The following is a description of a gene set: Genes having at least one occurrence of the highly conserved motif M79 WGGAATGY in the regions spanning 4 kb centered on their transcription starting sites. This matches the TEAD1 transcription factor binding site V$TEF1_Q6 (v7.4 TRANSFAC). Human Gene Set: WGGAATGY_TEF1_Q6 studied in species Homo sapiens from publication Xie X, Lu J, Kulbokas EJ, Golub TR, Mootha V, Lindblad-Toh K, Lander ES, Kellis M (PMID 15735639) Comprehensive identification of all functional elements encoded in the human genome is a fundamental need in biomedical research. Here, we present a comparative analysis of the human, mouse, rat and dog genomes to create a systematic catalogue of common regulatory motifs in promoters and 3' untranslated regions (3' UTRs). The promoter analysis yields 174 candidate motifs, including most previously known transcription-factor binding sites and 105 new motifs. The 3'-UTR analysis yields 106 motifs likely to be involved in post-transcriptional regulation. Nearly one-half are associated with microRNAs (miRNAs), leading to the discovery of many new miRNA genes and their likely target genes. Our results suggest that previous estimates of the number of human miRNA genes were low, and that miRNAs regulate at least 20% of human genes. The overall results provide a systematic view of gene regulation in the human, which will be refined as additional mammalian genomes become available., and this is the list of marker genes: MMP23A, PTMS, DLG3, MID1, PCBP1, RRAS, CDH3, ARHGAP24, NDST4, CHRNA1, SH3RF1, TENT5B, SEPTIN4, FGA, TSPAN9, SLC12A5, MMP1, LMNA, CRLF1, IL6ST, CDC42EP1, SPTB, EFNB3, DVL3, CACNA1G, VIT, NTF4, KLHDC3, FAM50A, HAND2, NUFIP2, RNF2, CPLX2, ZNF827, MYPN, HNRNPLL, NRG1, TRIM54 (tripartite motif containing 54), TFDP2, MAN1A2, MEA1, ADAM33, KCNE2, SLC26A6, SPRED1, CLDN16, TRAF4, SOSTDC1, GAS2L2 (growth arrest specific 2 like 2), TSPYL4, MAPRE3, PRRG4, CALHM4, GLP2R, ITGB1BP2, MNT, PGF, MDK, COA3, LIFR, MTSS1, GREM1, PRDM1, CYP2W1, LINC01567, FOXN1 (NCBI Gene Id 8456), MGLL, AP2M1, EPHA2 (NCBI Gene Id 1969), TGIF1, HOXC13, KRT14, DENND2B (DENN domain containing 2B), PTH1R, PGAM2, MLIP (muscular LMNA interacting protein), SYT2, EPCIP, LAMC2, HSPB2, ROGDI, RADIL, RHBDF1, CTTNBP2NL, PAQR6, RRN3P1, C10orf71, RAB30, NOTCH2NLA, PRUNE1, NFKB2, MPZ, COL5A3, SPDEF, CNN3, DIAPH1, CDK2, DACT1, ZNF462, INHBA, KALRN, PRKCI, IER5, CRYAB, LINC00482, NHERF1, RPH3AL, CHIC2, KLK6, DDX23, GALNT12, PTPRJ, SCARF2, CCN1, SIPA1, SIN3A, APOE, PPFIA1, ROCK2, PLS3, CAVIN1, SH2B3, PKP4, FOXP2, SORBS2, REST, CLRN1, PTCH1, SPEG, SPACA7, JUND, COL4A5, TNS2, CCDC148, ITGA3, PRSS27, CCN2, LRRN4CL (NCBI Gene Id 221091), HOXA10, MLLT3, CEND1 (NCBI Gene Id 51286), RNF19A, MGAT4C, CCSER2, ZC3H10, TMSB4XP1, WIPI1, SMOC2, GDI1 (GDP dissociation inhibitor 1), HOXB3, CALCOCO1, TBXT, NID1, SMAD3, SOST, WDR13, UNC13D, JADE1, DENND1B, MMGT1, ATRN (attractin), APPBP2, PLEKHH3 (pleckstrin homology, MyTH4 and FERM domain containing H3, NCBI Gene Id 79990), SLC5A2, DUSP7, OTX2, SGIP1, COLEC10, NTN3, TINAGL1, NES, SEC14L3, TMEM86A, COL4A6, SH3BP1, CFL2, PLPP5, POGZ, ANKRD11, ESR1, MAST2, SH3BGRL2, VCL, MUSK, KMT2E (lysine methyltransferase 2E (inactive)), KAT14, CDKN2C, ATF4 (activating transcription factor 4), CAVIN3, CORO6, NNMT, PDGFRA, ADPRHL1, TGIF2, GHRL, KCNJ13, ATP5MC2, ITPR3, NTN5, SH3BGRL3, FGFR2, ACTA1, MYADM, MBNL2, FSTL1, DALRD3, HMGA1, PRMT3, ESRP2, RBM47, DIS3L, SCN8A, AVPI1, RAPSN, MYLK3, CAV1, GPM6A, SLF2, HMGB2, LDLRAD4, NKAPD1, GABRB1, FGF13 (NCBI Gene Id 730528), LRRC1, OLFML3, RAB11B, SLC31A2, ITGB4, KATNB1, DCANP1, HOOK1, NEDD4, CLC, ZNF467, SMARCA2, TSPAN33, TMPRSS11A, POLR1G, PPFIBP1, TPM1 (NCBI Gene Id 7168), TBC1D10A, ACSL3, SCNN1A, RNF207, RGS3, NEXN-AS1 (NEXN antisense RNA 1), BMP10, SRPX2, TNNT2, SPARC, MTF2, C22orf31, MYH6, NR4A1, DMD, IRS4 (NCBI Gene Id 8471), RBMS3, SKIDA1, FHOD1, TRPM3, FAM53B, ID2, LHX4, CGN, PGAP2, BTF3, TXLNGY, POGK, PLSCR2, UPK1B (NCBI Gene Id 94967), ERG, DSP, NRG2, SIX4 (NCBI Gene Id 51804), MBD6, TIAL1, EDN1, NR4A3, NOG, ARID1A, IL17RE, PDE1A, MMP23B, RARG, PROP1, TMSB4XP8, MAPK10, CKS1B, ELOF1, GPR21, NSD1, HAPLN1, KIF1C, CTDSPL2, BMPR2, LMOD1, PMEL, LAMB2, CDK6, SPECC1, ARHGAP29, INCA1, SHC1, DDR1, SYT8, PRX, FGFR4, PLXNB1, HDGF, RASAL2, DDX3X, RASSF2, PROK2, CNTN6, CHD4, DMPK, KCNH2, ZIC1, CPNE1, NOTCH2, NAP1L5, PHF12, DDIT3, SLC12A4, AJUBA, C1orf21, MYH7, SIX5, BCL11A (NCBI Gene Id 55085), MCF2, CLDN2, ASXL1 (NCBI Gene Id 23393), MSX2, NR2E1, EHD1, FOXO3, CLEC18C, PCNX4 (NCBI Gene Id 64430), LIN28A, NDUFAF3, COL11A2, GPRC5C, SYTL2, PPIL4, TSPAN17, ANGPT1, TMSB4XP4, TMEM88, ZBED2, TMOD3, BMP5, PTPN11, BMP4, MRGPRF, NPVF, ITGB1, HTN1, BCAM (basal cell adhesion molecule (Lutheran blood group)), KIFC3 (kinesin family member C3), LAMB3, TMEM125, STARD3, FBXL13, JMJD1C, TRPC4, PDGFA, ELF3, SH3TC2, PIAS3, IGFBP6, POPDC2, ITGA2, FAT1, ARMC10, TMSB10, GOLGA1 (NCBI Gene Id 2800), CA14, FERMT1, TMSB4XP6, RASGRP2, PIK3C3, CNTD1, RAPGEFL1, ERBB2, SLC16A8, WWC2-AS2, KDM5A